Given this list of marker genes EPOR, SNCA, DUSP6, SLC39A9, GLE1, ATP8B2, UBBP1, SORBS3, JUN, SRPRA, ITGB1BP1, PACSIN1, WDR74, DGKH, SLC5A3, IL22RA1, SERPINB13, here is a description of the gene set: Genes whose expression peaked at 20 min after stimulation of MCF10A cells with serum. species: Homo sapiens from publication Amit I, Citri A, Shay T, Lu Y, Katz M, Zhang F, Tarcic G, Siwak D, Lahad J, Jacob-Hirsch J, Amariglio N, Vaisman N, Segal E, Rechavi G, Alon U, Mills GB, Domany E, Yarden Y (PMID 17322878) Human Gene Set: AMIT_SERUM_RESPONSE_20_MCF10A Signaling pathways invoke interplays between forward signaling and feedback to drive robust cellular response. In this study, we address the dynamics of growth factor signaling through profiling of protein phosphorylation and gene expression, demonstrating the presence of a kinetically defined cluster of delayed early genes that function to attenuate the early events of growth factor signaling. Using epidermal growth factor receptor signaling as the major model system and concentrating on regulation of transcription and mRNA stability, we demonstrate that a number of genes within the delayed early gene cluster function as feedback regulators of immediate early genes. Consistent with their role in negative regulation of cell signaling, genes within this cluster are downregulated in diverse tumor types, in correlation with clinical outcome. More generally, our study proposes a mechanistic description of the cellular response to growth factors by defining architectural motifs that underlie the function of signaling networks.